Given this list of marker genes Akr1c21, Cyp46a1, Cyp39a1, Slc27a5, Akr1d1, Cyp8b1, Akr1c6, Hsd3b7, Slc27a2, Akr1c20, Cyp27a1, Amacr, here is a description of the gene set: studied in species Mus musculus Synthesis of bile acids and bile salts via 24-hydroxycholesterol Mouse Gene Set: REACTOME_SYNTHESIS_OF_BILE_ACIDS_AND_BILE_SALTS_VIA_24_HYDROXYCHOLESTEROL